Given this list of marker genes Plekho1, Camk1, Adam9, Scgb3a1, Tnfsf14, Dcstamp, Il4, Stat1, Tyrobp, Cd53, Ripor2, Cxcl12, Adgrb1, Nfatc2, Ehd2, Gcm1, Trem2, Capn2, Cxcl10, Nfe2, Ehd1, Ocstamp, Cxcl9, Tmem182, Ccl8, Flt3l, Il36g, Mapk14, Gdf15, Flot1, Myod1, Il4ra, Cflar, Myog, Rapgef3, here is a description of the gene set: Mouse Gene Set: GOBP_REGULATION_OF_SYNCYTIUM_FORMATION_BY_PLASMA_MEMBRANE_FUSION Any process that modulates the frequency, rate or extent of the formation of a syncytium, a mass of cytoplasm containing several nuclei enclosed within a single plasma membrane, by the fusion of the plasma membranes of two or more individual cells. studied in species Mus musculus